The following is a description of a gene set: Diffuse alveolar hemorrhage species: Homo sapiens A type of of pulmonary hemorrhage that originates from the pulmonary microcirculation, including the alveolar capillaries, arterioles, and venules. It presents with hemoptysis, anemia, diffuse lung infiltration, and acute respiratory failure. The diagnosis is confirmed by the observation of the accumulation of red blood cells, fibrin, or hemosiderin-laden macrophage in the alveolar space on pathologic biopsy. Hemosiderin, a product of hemoglobin degradation, appears at least 48-72 hours after bleeding and is helpful in distinguishing diffuse alveolar hemorrhage from surgical trauma. Mild interstitial thickening, organizing pneumonia, or diffuse alveolar damage can also be seen. Human Gene Set: HP_DIFFUSE_ALVEOLAR_HEMORRHAGE, and this is the list of marker genes: COL3A1, NABP1, PML, ZBTB16, STAT5B (signal transducer and activator of transcription 5B), HLA-DPA1, CTLA4, HLA-DPB1, PRKAR1A, STAT3, TBL1XR1, FIP1L1, PTPN22, PRTN3, HMOX1, NPM1, IRF2BP2, NUMA1, BCOR, PDCD1, RARA, EIF2AK4, NLRC4